Given this list of marker genes SHOC2, TTYH1, LRRC8E, CLCN2, LRRC8D, TTYH3, TTYH2, LRRC8A, LRRC8C (leucine rich repeat containing 8 VRAC subunit C), CLCN3, LRRC8B, here is a description of the gene set: Enables the transmembrane transfer of a monoatomic anion by a volume-sensitive channel. A volume-sensitive channel is a channel that responds to changes in the volume of a cell. Human Gene Set: GOMF_VOLUME_SENSITIVE_ANION_CHANNEL_ACTIVITY studied in species Homo sapiens